Given this list of marker genes Hsh2d, Lss, H2ax (H2A.X variant histone), Man1c1, Zkscan8, Orc5, Pcbp4, Exoc2, Glmn, Lig1, Tbc1d22a, here is a description of the gene set: Mouse Gene Set: CUI_MAST_CELL_ADIPONECTIN_RESPONSE_UP Cytokines mediate cell-cell communication in the immune system and represent important therapeutic targets. A myriad of studies have highlighted their central role in immune function, yet we lack a global view of the cellular responses of each immune cell type to each cytokine. To address this gap, the authors created the Immune Dictionary, a compendium of single-cell transcriptomic profiles of more than 17 immune cell types in response to each of 86 cytokines (>1,400 cytokine-cell type combinations) in mouse lymph nodes in vivo. A cytokine-centric view of the dictionary revealed that most cytokines induce highly cell-type-specific responses. For example, the inflammatory cytokine interleukin-1β induces distinct gene programmes in almost every cell type. A cell-type-centric view of the dictionary identified more than 66 cytokine-driven cellular polarization states across immune cell types, including previously uncharacterized states such as an interleukin-18-induced polyfunctional natural killer cell state. Genes positively differentially expressed in cell type: Mast cell upon treatment with cytokine: AdipoQ in mouse lymph nodes in vivo. from publication Cui A, Huang T, Li S, Ma A, Pérez JL, Sander C, Keskin DB, Wu CJ, Fraenkel E, Hacohen N (PMID 38057668) studied in species Mus musculus